Given this list of marker genes Gck, Cartpt, Gabbr1 (NCBI Gene Id 54393), Ptgs1, Crh, Crhr1, Crhr2, here is a description of the gene set: Any process that modulates the frequency, rate or extent of the regulated release of epinephrine. species: Mus musculus Mouse Gene Set: GOBP_REGULATION_OF_EPINEPHRINE_SECRETION